Given this list of marker genes TENT4B, ZFP36L2, PDE12, SAMD4B, CNOT6, EIF4ENIF1, TENT4A, PABPC1, YBX1, POLR2G, PATL1, HNRNPU, CNOT11, CNOT2, MLH1, NOCT, CNOT7 (CCR4-NOT transcription complex subunit 7), RC3H1, ZFP36, PABPN1L, SYNCRIP, PNLDC1, HNRNPD (NCBI Gene Id 548), AGO2, PAN3, DHX36, PAIP1, CPEB3, SAMD4A, TNRC6C, LSM1, CNOT6L, DCP1B, DCP1A, TNRC6A, TOB1, CSDE1, CNOT1, DCPS (decapping enzyme, scavenger), TNKS1BP1, CNOT9, IGF2BP1, DIS3, DCP2, CNOT4, CNOT8, BTG2, RC3H2, PAN2, PATL2, DHX9, CAPRIN1, NT5C3B (5'-nucleotidase, cytosolic IIIB), CNOT10, ZFP36L1, PARN, TNRC6B, CNOT3, here is a description of the gene set: Human Gene Set: GOBP_NUCLEAR_TRANSCRIBED_MRNA_CATABOLIC_PROCESS_DEADENYLATION_DEPENDENT_DECAY A major pathway of degradation of nuclear-transcribed mRNAs that proceeds through a series of ordered steps that includes poly(A) tail shortening and that can regulate mRNA stability. species: Homo sapiens